Given this list of marker genes APOC2 (NCBI Gene Id 344), STX4, LCK, PDGFRA (platelet derived growth factor receptor alpha), ARHGAP6, CCL8, BTK, CCL3, GM2A, FYN, PDPK1, CASP3, SRC, CCL5, ARF4 (NCBI Gene Id 378), PLAA, HRAS (NCBI Gene Id 338029), ARL1, PDGFRB, here is a description of the gene set: Human Gene Set: GOMF_PHOSPHOLIPASE_ACTIVATOR_ACTIVITY studied in species Homo sapiens Binds to and increases the activity of a phospholipase, an enzyme that catalyzes of the hydrolysis of a glycerophospholipid.